Given this list of marker genes Sptlc2, Psap, St8sia5, St3gal5 (NCBI Gene Id 20454), M6pr, Fut2, Cerk, Abcg2, Smpd1, Neu1, Sumf2, Glb1l3, Smpd2, Cyb5b, Aldh3b1, Neu3, Arsi, Asah2, Smpd4, B4galt6, Plpp1, Spns2, Kdsr, Ormdl3, Glb1l2, Hexa, St3gal2, Hexb, Degs2, Arsa, Sumf1, Gba1, Arsg, Glb1l, Neu4, Aldh3b2, St6galnac6, Fut1, Sptlc3, B3galnt1, Sts, St3gal3, Plpp2, B3galt4, Sgpp2, Sgpl1, Arsj, Neu2, Fa2h, Sptssb, Cers1, Ormdl2, Gba2, Cers5, Cers4, Sgpp1, here is a description of the gene set: This event has been computationally inferred from an event that has been demonstrated in another species.<p>The inference is based on the homology mapping from PANTHER. Briefly, reactions for which all involved PhysicalEntities (in input, output and catalyst) have a mapped orthologue/paralogue (for complexes at least 75% of components must have a mapping) are inferred to the other species. electronically inferred by orthology from the curated human pathway part of: Metabolism of lipids Reactome Pathway: Sphingolipid metabolism studied in species Mus musculus